Given this list of marker genes SELENOW, PIM2, KCTD10, ALYREF, SNRNP40, GOLM1, CRADD, SELP, OXCT1, GUSB, ZDHHC14, PGAM1, ATP8A1 (NCBI Gene Id 10396), ERP29, ATP6V0A2, COL2A1, FRG1, TBC1D14, SLC3A2, ABCB10, TRIM13, ASNSD1, OSTF1, SHMT1, WDR43, ENTPD1, S100A10, DMRTB1, NF2, ELF1, PSTPIP2, DENND4C, STYX, ACKR1, TANC1, METTL9, TERT, ELAVL4, CCT7, DDOST, APEX1, KCTD12, PPP1R2P1, SNRPA1, ATP6V1H, SWI5, CRYBG1, NDUFA9, SMU1, EPHA6, PLA2G10, PRPSAP2, PLAC8, NFIA, CHMP3 (charged multivesicular body protein 3), PARL (presenilin associated rhomboid like), MOCS2, GSN, CD244, ACOT9, PES1, CACNA2D3, LAPTM4B, FAM216A, RSU1, ATG5, QRSL1, HOXA1, CST7, JPT1, IRAG2, HEXA, BLVRA (biliverdin reductase A), FCGR1A, KANSL2, CREB1, COPS4, XRCC5, MNAT1, EXOSC7, TIMM9, NUP93, RWDD4, GANAB, ST6GALNAC2, GLO1, PPM1A, CRYM, DPH5, TPK1, CTNND2, LIFR, DNAJB1, PGRMC1, EFNA5, BCAS2, SAE1, ARFRP1, SKIC8, PRELID3B, RRM2 (NCBI Gene Id 6241), COQ7, TMEM147, PSMG2, SLC25A3, ST3GAL6, DDX3Y, PFDN2, KRAS, IDUA, NDUFA10, SCAF11, CFDP1, PDLIM4, IQGAP2, SAR1B, ITPR1, RNASEH2B, FAM241A, ALG2, LIMK2, SUCLG2, PCBP1, AQP9, SPRYD4, TMEM71, THOC3, S100A4, MAGOH, WDR55, PSPH, EIF4B, SKAP2, RAB8A (RAB8A, member RAS oncogene family), EIF2A, CDCA4, DLST, NDRG1, ANTXR2, PPIC, C5orf15, KIF9, PNO1, SLC7A6, SLC35A4, CCT3, ADH5, LMO4 (NCBI Gene Id 8543), PPIH, NFE2L2, GLRX3, NPY2R, PRDX3, NEFH, EEF1D, FRMD8, RRP1B, SOCS2 (NCBI Gene Id 8835), SERPINI1, HOXA13 (NCBI Gene Id 3209), GALK1, CTPS1, ZAN, ENTPD5, NTPCR, DRAP1, DPCD, SNX9, NDUFV1, SRSF9, IL7R, E2F3, CHIC1, H2AB2, FARSA, RAB28, SNX1, FH, CYP27B1, SHOC2, WDR77, MLLT10, RNF112, GSTK1, ARF4, SOD2, CLNS1A, KCNJ15, TMEM229B, CMAS, OCIAD1, CCNDBP1, NUDT16L1, F2RL3, ACTL6A, PSMD13, PEBP1, RXYLT1, GLCE (glucuronic acid epimerase), here is a description of the gene set: We wanted to test the role of mammalian E proteins E2A and HEB in the development of T cells. Using a conditional deletion system in which these proteins are deleted at the DP stage of T cell development, we compared DP thymocytes deficient for E2A, HEB or both to wild-type thymocytes Genes down-regulated in double positive thymocytes: wildtype versus TCF12 knockout. species: Homo sapiens Human Gene Set: GSE19923_WT_VS_HEB_KO_DP_THYMOCYTE_DN from publication D'Cruz LM, Knell J, Fujimoto JK, Goldrath AW (PMID 20154672)